The following is a description of a gene set: Human Gene Set: GOMF_HEXOSAMINIDASE_ACTIVITY Catalysis of the cleavage of hexosamine or N-acetylhexosamine residues (e.g. N-acetylglucosamine) residues from gangliosides or other glycoside oligosaccharides. studied in species Homo sapiens, and this is the list of marker genes: GM2A, HEXD, HEXA, HYAL3, NAGPA, CEMIP, HYAL4, OGA, NAGLU, HYAL2, NAGA, CEMIP2, HEXB, SPAM1, HYAL1